Given this list of marker genes Nr4a2, Ier5, Fosb, Jund, Pmaip1, Klf4, Fos, Atf3, Nr4a1, Kctd12, Btg1, Zfp36, Jun, Zfp36l1, Klf2, Dusp1, here is a description of the gene set: species: Mus musculus from publication Cui A, Huang T, Li S, Ma A, Pérez JL, Sander C, Keskin DB, Wu CJ, Fraenkel E, Hacohen N (PMID 38057668) Cytokines mediate cell-cell communication in the immune system and represent important therapeutic targets. A myriad of studies have highlighted their central role in immune function, yet we lack a global view of the cellular responses of each immune cell type to each cytokine. To address this gap, the authors created the Immune Dictionary, a compendium of single-cell transcriptomic profiles of more than 17 immune cell types in response to each of 86 cytokines (>1,400 cytokine-cell type combinations) in mouse lymph nodes in vivo. A cytokine-centric view of the dictionary revealed that most cytokines induce highly cell-type-specific responses. For example, the inflammatory cytokine interleukin-1β induces distinct gene programmes in almost every cell type. A cell-type-centric view of the dictionary identified more than 66 cytokine-driven cellular polarization states across immune cell types, including previously uncharacterized states such as an interleukin-18-induced polyfunctional natural killer cell state. Mouse Gene Set: CUI_CDC1_NOGGIN_RESPONSE_DN Genes negatively differentially expressed in cell type: cDC1 (conventional dendritic cell type 1) upon treatment with cytokine: Noggin in mouse lymph nodes in vivo.